The following is a description of a gene set: Non-canonical inflammasome signaling pathway. Pathway ID: N00934. Pathway type: Reference. Pathway class: nt06521 NLR signaling. Pathway Definition from KEGG: LPS -> CASP4/5 -> (NLRP3+PYCARD+CASP1) -> (IL1B,IL18) Human Gene Set: KEGG_MEDICUS_REFERENCE_NON_CANONICAL_INFLAMMASOME_SIGNALING_PATHWAY species: Homo sapiens, and this is the list of marker genes: NLRP3, CASP4, CASP1, PYCARD, CASP5, IL1B, IL18